The following is a description of a gene set: Mouse Gene Set: chr13C2 species: Mus musculus, and this is the list of marker genes: Gm24635, Gm8345, Arrdc3, 1700023H06Rik, Gm32067, Gm5197, Gm25383, Gm8371, Gm19320 (NCBI Gene Id 100502682), Gm46388